Given this list of marker genes SLC25A13, SLC25A12, SLC32A1, SLC38A5, SLC38A3, here is a description of the gene set: Human Gene Set: GOMF_AMINO_ACID_MONOATOMIC_CATION_ANTIPORTER_ACTIVITY species: Homo sapiens Enables the transfer of a solute or solutes from one side of a membrane to the other according to the reaction: solute(out) + monoatomic cation(in) = solute(in) + monoatomic cation(out). Monoatomic cations include H+, Mg2+, Ca2+, etc.